The following is a description of a gene set: Mouse Gene Set: GOBP_L_LEUCINE_IMPORT_ACROSS_PLASMA_MEMBRANE The directed movement of L-leucine from outside of a cell, across the plasma membrane and into the cytosol. species: Mus musculus, and this is the list of marker genes: Slc3a2, Slc43a1, Slc7a8, Slc43a2, Slc7a5